Given this list of marker genes UROD, ABCB10, DMTN, BACH1, MAFK, FTL, HMBS, GSTT2, ANK1, STOM, UROS, ALAD, HBA2, NFE2, ZFPM1, KLF1, ALAS2, HBZ, GYPA, SLC4A1, HBD, MAFG, HBE1, PPOX, TFRC, here is a description of the gene set: from publication Welch JJ, Watts JA, Vakoc CR, Yao Y, Wang H, Hardison RC, Blobel GA, Chodosh LA, Weiss MJ (PMID 15297311) studied in species Mus musculus Transcription factor GATA-1 is required for erythropoiesis, yet its full actions are unknown. We performed transcriptome analysis of G1E-ER4 cells, a GATA-1-null erythroblast line that undergoes synchronous erythroid maturation when GATA-1 activity is restored. We interrogated more than 9000 transcripts at 6 time points representing the transition from late burst forming unit-erythroid (BFU-E) to basophilic erythroblast stages. Our findings illuminate several new aspects of GATA-1 function. First, the large number of genes responding quickly to restoration of GATA-1 extends the repertoire of its potential targets. Second, many transcripts were rapidly down-regulated, highlighting the importance of GATA-1 in gene repression. Third, up-regulation of some known GATA-1 targets was delayed, suggesting that auxiliary factors are required. For example, induction of the direct GATA-1 target gene beta major globin was late and, surprisingly, required new protein synthesis. In contrast, the gene encoding Fog1, which cooperates with GATA-1 in beta globin transcription, was rapidly induced independently of protein synthesis. Guided by bioinformatic analysis, we demonstrated that selected regions of the Fog1 gene exhibit enhancer activity and in vivo occupancy by GATA-1. These findings define a regulatory loop for beta globin expression and, more generally, demonstrate how transcriptome analysis can be used to generate testable hypotheses regarding transcriptional networks. Genes up-regulated after GATA1 activation in G1E-ER4 cells (erythroid precursors engineered to express GATA1 upon addition of estradiol). Human Gene Set: WELCH_GATA1_TARGETS